The following is a description of a gene set: species: Mus musculus Any process that activates or increases the frequency, rate or extent of the process of creating protein polymers. Mouse Gene Set: GOBP_POSITIVE_REGULATION_OF_PROTEIN_POLYMERIZATION, and this is the list of marker genes: Ccl11, Gm14137, Grb2, Csf3, Hsp90aa1, Cdkn1b, Akap9, Pycard, Cttn, Nav3, Mapk8, Snx9, Evl, Mlst8, Hspa1a, Map3k1, Actr3, Cdk5rap2, Slain1, Lmod2, Clip1, Ccl24, Psrc1, Prkce, Dctn1, Ccl21f, Alox15, Arpc2, Tppp3, Ccl21d, Ttbk1, Baiap2l1 (NCBI Gene Id 66898), Cav3, Ccl21b, Pak1, Carmil1, Arf6, Git1, Cdc42ep5, Cdc42ep4, Nckap1l, Rac1, Cdc42ep2, Ckap5, Vasp, Fer, Met, Mecp2, Bin1, Map1b, Hspa1b, Carmil2, Tppp, Fchsd2, Ptk2b, Cdc42ep1, Pfn1, Baiap2, Lmod1, Dlg1, Myo1c, Mapt, Ccl21a, Rhoa, Kirrel1, Nck2, Cav1, Cdc42ep3, Nphs1, Numa1, Fmn1, Cracd, Ccl26 (C-C motif chemokine ligand 26), Togaram1, Tppp2, Rictor, Baiap2l2, Nckap1, Tenm1, Fchsd1, Drg1, Fes, Apc, Slain2 (SLAIN motif family, member 2), Mapre1, Pfn2, Pde4dip, Ambra1, Bag4, Gda, Arl2, Rps3, Ccl21e, Ankrd53, Nck1, Icam1, Mtor